Given this list of marker genes Tbx1, Phldb1, Schip1, Kat6a, Ihh, Gnas, Mab21l2 (mab-21-like 2), Specc1l, Mmp2, Rab3gap1, Cdk2ap1, Crispld2, Plekha1, Twist2, Crebbp, Lef1, Ankrd11, Msx1, Nipbl, Csrnp1, Nckap1, Grem2, Ift122, Pax9 (NCBI Gene Id 18511), Nog, Cdon, Ssbp3, Phldb2, Braf, Gpc3, Ski, Tgfb1, Zfp950, Stra6, Asph, Zfp640 (zinc finger protein 640), Wnt3, Rras, Dlx5, Pdgfra, Sgpl1, Crispld1, Clasp2, Tgfb3, Fuz, Arid5b, Zfp281, Lrp6, Ep300, Tfap2a, Prickle1, Dag1, Tcf7l2, Atp6ap2, Flvcr1, Tiparp, Scx, Tgfb2, Vps13b, Ptpn11, Dkk1, Gatad2a, Col1a1, Clasp1, Ofd1, here is a description of the gene set: studied in species Mus musculus Mouse Gene Set: GOBP_BODY_MORPHOGENESIS The process in which the anatomical structures of the soma are generated and organized.